Given this list of marker genes PIGV, ALG2, PIGB, PIGM, ALG11, here is a description of the gene set: Human Gene Set: GOMF_GLYCOLIPID_MANNOSYLTRANSFERASE_ACTIVITY Catalysis of the transfer of an alpha-D-mannosyl residue from GDP-mannose into lipid-linked oligosaccharide, forming an alpha-D-mannosyl-D-mannose linkage. species: Homo sapiens